The following is a description of a gene set: from publication Cao J, O'Day DR, Pliner HA, Kingsley PD, Deng M, Daza RM, Zager MA, Aldinger KA, Blecher-Gonen R, Zhang F, Spielmann M, Palis J, Doherty D, Steemers FJ, Glass IA, Trapnell C, Shendure J (PMID 33184181) The gene expression program underlying the specification of human cell types is of fundamental interest. The study authors generated human cell atlases of gene expression and chromatin accessibility in fetal tissues. For gene expression, the study authors applied three-level combinatorial indexing to >110 samples representing 15 organs, ultimately profiling ~4 million single cells. The study authors leveraged the literature and other atlases to identify and annotate hundreds of cell types and subtypes, both within and across tissues. Our analyses focused on organ-specific specializations of broadly distributed cell types (such as blood, endothelial, and epithelial), sites of fetal erythropoiesis (which notably included the adrenal gland), and integration with mouse developmental atlases (such as conserved specification of blood cells). These data represent a rich resource for the exploration of in vivo human gene expression in diverse tissues and cell types. Human Gene Set: DESCARTES_MAIN_FETAL_ASTROCYTES Marker genes curated from the annotated cluster as represented in the Descartes Human Gene Expression During Development database. species: Homo sapiens, and this is the list of marker genes: MMD2, WARS2-IT1, PTN, FGFBP3, HEPACAM (hepatic and glial cell adhesion molecule), SNCAIP, SLC6A11, LINC02568, CYP26A1, CKAP2LP1, LINC00446, BOC, NCKAP5-IT1, PCDH8, NRXN1-DT, GFAP, SLC25A48, LGR6, RGS20, CYP4F24P (cytochrome P450 family 4 subfamily F member 24, pseudogene), RFTN2, CYP26B1, RFX4, RNGTTP1, ADGRG1, CYP26C1, FZD10, WNT3, OTOG, CACHD1, WIPF2, ST8SIA1, DCLK2, LINC02883, ELOVL2-AS1, RNU6-1331P, ZNF863P, ATP1A2, NHSL1-AS1, ADCYAP1R1, C2CD5-AS1, RNY1P5, EEF1DP3, PAX3, DBX2 (NCBI Gene Id 440097), GPM6B, C1QL4, RPS20P22, CCDC140, PHYHIPL, PTCH1